Given this list of marker genes AP2B1, LRP6, PTPRO, ATCAY, ABHD17B, RIC3, STXBP3, QKI, AP3M2, ADAM10, CD53, NRG3, CAPZB, CNTNAP4, LRFN1, GABRA1, NOS1, PAK2, PTK2B, RALA, SEMA7A, SYNE1, KCNC2, GRIA2, GRIN1, RPL10A (NCBI Gene Id 4736), HTR3D, C1QBP, CALM1, C9orf72, CTNNB1, CNTN6, HCRTR2, EPHB1, EEF1A2, MIB1, GRIN3B, CRHR2, GRK2, VPS35, TULP1, ADGRL2, RAB11B, ATP6V1C1 (ATPase H+ transporting V1 subunit C1), OGT, RGS7BP, SH2D5, C1QA, DLG5, KPTN, SYN3, CNTNAP2, MTMR2, GNG13, KCNMA1, SYNJ2, AP3S1, ERBIN (NCBI Gene Id 55914), GRM1, ATP1B2, AKR1A1, NGFR, GPC1 (glypican 1), SPG11, ATP6V1A, PTPRS, ENAH, KCNN1, BEST1, SYN1, SIPA1L2, RPH3AL, PHAF1, PCBP1, NPTXR, KCNIP2, GABRB3, ARHGAP22, ANK3, PARK7 (NCBI Gene Id 113880), ADORA2B, MFF, TRIO, LAMA2, SLC16A1, YWHAH, GPR158, BCAN, NECTIN1, GNG12 (G protein subunit gamma 12), ADGRL3, SNAP23, CHRM5, MAGI2, KCNMB4, SYT10, SPOCK1, PPFIA3, PVALB, CPNE4, SIGMAR1, SLC30A1, GNG3, LNX1, PORCN, PPA2, CLMP, FXR1, RTN3, AP3B2, LINGO2, DISC1, ATG9A, GABBR2, SLC40A1, NTRK2, VAMP4, RPL30, FLNA, SH3GL1, RAB5A, GNAI2, STX2, RHEB, SLC6A1, ARHGAP12, TAGLN3, CACNB2, VTI1B, TRIM9, CNR2, IGF2BP1, GPHN, RPS20, ICAM5, NIPSNAP1, NF1, FAM81A, KALRN, ATP7A, KCNMB1, SLC1A7, ELFN2 (extracellular leucine rich repeat and fibronectin type III domain containing 2), MEF2C (NCBI Gene Id 4208), ACTL8, DBH, LRRC7, SCGN, SNAP91, SNAP29, GRIK2, DGKI, RPS3A (NCBI Gene Id 6189), CRTAC1, APBA1, CHRNA7, SYT13, EPS15, SPTBN1, TRPV1, DOCK1, ARL8B, CAPN2, DNAJC5, GPC2, KIF17, GDI1, ITGA3, RANBP6, FMR1, PAK5, PPP3CA, ACTB (actin beta), RAB40AL, NEDD8, CNP, PTPN1, PTPRD, SEPTIN4, PIAS3, CDH1, CNTN5, NPTX1, AGRN, MAPK8IP1, OMP, NEURL1 (neuralized E3 ubiquitin protein ligase 1), RAP1B, SLC12A5, OPRD1, ABHD6, TRAPPC4, GNAQ, NEO1 (neogenin 1), PGRMC2, NTS, GUCY1A1, BCL11A, VANGL2, METTL5, CDH6, CRK (CRK proto-oncogene, adaptor protein), ADARB1, HRH4, ATP2B1, GSK3B, GPR50, CAV3, TNR, RYK, ATP6V1G2, SRPK2, PLAA, KCNC3, SNCA, NTF4, KCNB1, ATP8A1, SYNJ1 (NCBI Gene Id 8867), CPT1C, SYAP1, VPS18, SRCIN1, MBP, EFNB1, YWHAG (NCBI Gene Id 96443), CORO1B (coronin 1B), TUBA1A, SNTB2, SEPTIN3, LASP1, CPSF2, NRGN, FLOT1, CAMK2N2, LRRC4B, CACNB3 (calcium voltage-gated channel auxiliary subunit beta 3), EPS8, IGSF21 (NCBI Gene Id 84966), ARHGDIA, CNR1, LIN7A, P2RX1, HTR3A, HOMER3, APBB2, LRIT1, ADRA2A, NWD2, LAMB2, CDK16, GAD2, PPP1CC, C1QL2, SLC1A3, ATP6V1E1, SLC24A2, ITSN1, PPP3R1, ATP1A3, NCKIPSD, NCAN, C1QL3, DLGAP2, USP5, ATP6AP1, RPL7, MINK1, RAPGEF4, EEA1, UBE2M, DGKZ, SYNDIG1, PLCB3, CALB2, PDE2A, HTT, P2RY1, PTCH1, SNX27, GPR176, CHRNA2 (NCBI Gene Id 1135), CTNND2, UNC5C, PJA2, LAMA5, PTPRN, NMNAT2, PCDHB11, CXADR, LRP4, PRKAR1A, SEZ6 (seizure related 6 homolog), SLC22A2, CLN8, YWHAZ, NDEL1, AAK1, ARFGAP1, EPHA7, CBARP, CHRNG, SLC6A9, STX11, ATP6V1G3, CACNG2, SPARCL1, BLTP1, SLC30A10, TOR1A, SYT6, CDKL5, SEMA3A, NEGR1, SNX9, OPHN1, ZDHHC2, RPS11, GAK, NSF, VAMP1, GABRG3, RAB40B, SRPX2, STX7, SLC1A2, MPP2, SLURP2, CLN3, HAPLN3, CRMP1, APH1A, RPL28, RPH3A, SLC6A17, SNPH, CRYAB, KCNJ10, CAMK2D, SV2A, SPTBN2, BAIAP3, BAIAP2, VASP, RPS16, GABRA5, SLC35G2, CDH10, SLC18A2, GPRIN3, CRELD1, RPL12, TANC2, CANX, WHRN, SLC1A4 (NCBI Gene Id 6509), FILIP1, RAB5B (RAB5B, member RAS oncogene family), CLSTN3, PCDHB2, KCNC4, P2RX3, LY6G6D (NCBI Gene Id 58530), RPS27, PMP22, ATG16L1, RASGRP2, CLCN5, GNAZ, DAPK1, ATP6V0C, ZNF804A, SLITRK3, SENP1, SYPL2, AP2M1, DGKE, SERPINE2, AP3M1, ABI3, MX1, SRGAP2C, LRRTM4, CHN2, SOS1, PACSIN2, DSCAML1, MCTP2, CC2D1A, EHD1, APOE (apolipoprotein E), KCNQ3, VAMP3, GPER1, PPFIA2, CRH, SYNGR1, SDK1, GRM2, VAMP7, DAAM1, MYO7A, SHISA7, NR1D1, SLC8A3, AKAP12, CALM3, ADRB1, FGF22, CACNA1C, BTBD8, STXBP2, NEFH, NXPH4, TPRG1L, NOS1AP, GNRH1, DNM1L, PTN, RGS8, ZDHHC12, NECAP1, ATP6V1F, SORBS2, SLC3A2, KCNJ2, TIAM2, PNKD, RPS6, HTR6, ITPR1, ADORA1, HAPLN1, PRKCI, PKP4, PPP2CA, VWC2, CLTA, ATM, MAF1, ROGDI, YWHAQ, GNB1, LATS1, KCTD16, MAP1B, ATP2B3, SNX14, HNRNPUL1, CDK5R1, CAMK2N1, MUSK, CDH15, PPP1R9A, SLC2A1, PFN1, LYN (NCBI Gene Id 4067), P2RX2, EIF4E, LARGE1, GRIN3A, NCK2, SEMA4F, CAPRIN1, NECAB2, RPS6KA1, GLRA1, NLGN4Y, RPL37, INSYN2A, LZTS1, TRIM47, SACM1L (SAC1 like phosphatidylinositide phosphatase), PSD, CACNA1G, GIPC1, SORT1, CHRM1, TMED9, CLCN2, DSTN, UBE3B, SDK2, SYDE1, ZDHHC5, PDLIM4, SLC32A1 (solute carrier family 32 member 1), HOMER2, TIAM1, FER1L5, EFR3A, DAGLA (diacylglycerol lipase alpha), CADPS, EIF5A, PCDHB16, PACSIN1, ARL8A, NRG1, SST, GABRA2, CPLX1, EGFLAM, RPL38, HPCA, BNIP3, PICK1, FGB, GLS, EFNB2, SYNGAP1, STAU2, APBA3, PCDHB13, PLS3, SIPA1L1, PRKN, DACT1, PRRT1, CAPN5, ARPC5L, EGLN1, RPL27A, CHRM4, HRAS, CIB2, MYO9B, PCDHB3, HNRNPA1, ARHGAP32, CHRNA4, ABHD17C, INPP4A, ARPC1A, RPS5, PHF24, CHRNA1, ADCY1, ARHGEF15, KIF2C, F2R, EIF3D, KCNQ2, AURKA, CD3E, GAP43 (NCBI Gene Id 2596), PALM, RGS9, PCLO, TENM2, CRIPT, TPGS1, USP46, LPAR3, CPEB3, PIAS1, AP1S1 (NCBI Gene Id 574017), GRN, FXYD6, WASF1, AKAP5, PRNP, RIMS1, DDN, MICAL1, SH3KBP1, SORCS2, HNRNPA0, NAPA, CPEB1, DLG2, TSC1, CHRND, SDCBP, SLC12A7, CASK, PIK3C3, ALDH5A1, ATP6V1H, NPFF, PRUNE2, SLC1A6, KCNQ5, TDRD1, ANO1, PLXNA1, PRR12, C1QC, DGKQ, UBE3A, SLC29A4, SMCR8, NPBWR1, PRKCB, RGS12, NGF, SNX4, VLDLR, SUMO2, DTNB, RTN4R (reticulon 4 receptor), EIF4EBP2, WNT3A, SHARPIN, ZDHHC8, IL1RAPL2, CNIH2, EEF2, NLGN2, OLFM3, SLC4A8, ZNRF2, SYPL1, MYRIP, SLC35F1, NSMF, ATG5, CPLX3, HRH3, SSH1, PAFAH1B1, MET, P2RX6, ATP2B2, ASIC1, ATP6V1D, PCDHB10, GNG7, RPL34, LAMP1, HTR2A, NPS, NLGN4X (neuroligin 4 X-linked), SLC17A6, KIF5B, EPS15L1, PPP3CB, OXT, RIT2, ACTG1, SHISA9, BAALC, NPPA, GPSM2, DNMBP, PPP1CA, ARF1, ABI1, SRGAP2B, CHRNA5, FAIM2, MPDZ, NEFM, EFNA2, ENO2, CALM2, MYCBPAP, VPS45, DOCK4, C4A, SNAP25, FCHO1, NRP2, MYO9A, VAMP2, AGAP3, C4B, UNC119, PPFIBP2, PPFIBP1, TANC1, HIP1, GNA13, CADPS2, SCN2B, GRIK5, CBLN3, NR3C1, GSK3A, GHSR, PSEN2, SEMA3F, STRN, HTR1A, SLC8A2, RPL31, CDH8, CAD, MYOF, GNB4, PPFIA4, FAM107A, ATP1A1, MCTP1, CHRNB3, LRRTM1, NPY2R, FLRT2, SNX6, SYP, SLC29A1, CD2AP, AP1G1, GRM6, SLC18A3, ADGRB2, COLQ, IGSF9, SLC2A4, ROR1, AKT1 (NCBI Gene Id 207), RAC3, EXT1, ARHGAP33, ABLIM3 (NCBI Gene Id 22885), DNM1, NAPEPLD, EPHB2, NPY5R, TRAF6, SLITRK4, ARR3, LRFN5, SH3GL3, NCDN, SLC2A13, P2RX4, GRIK1, VPS52, KCNA4, RGS7, AKAP7, RPL21, NTF3, PLD1, FLOT2, LRRTM3, RPS28, FCGR2B, RPL19, PDZRN3, CACFD1, IQSEC3, SHANK2, SEPTIN11, NQO1, ADAM22, MAP2K1, KCNJ4 (potassium inwardly rectifying channel subfamily J member 4), RPS3, PSD2, ARF6, ERC2, GABRG2, SGIP1, STAU1, CBLN4, AP2A2, AMOT, ACP1, PCDHB9, DMXL2 (NCBI Gene Id 23312), TMEM230, CABP4 (calcium binding protein 4), GRIP1, MAPK14, GLRA2, VWC2L (von Willebrand factor C domain containing 2 like), TNC, PSCA, SYT12, RPL7A, ATP6V0D1, SLITRK2, GRIA1, CHRNA9, CEP89, NRXN1, TSC2, MAPT, SYT9, ELMO1, RIMS2, SRSF10, ATP6V1G1, SCAMP5, CNTNAP1, SPHK1 (NCBI Gene Id 8877), RABEP1, ACTN1, TSPOAP1, SLC9A5, MTNR1B, KCNJ9, WASF2, CHRNB4, KIRREL3, POTEJ, LRRC4C, ACTC1, SLC6A13, LRRK2, GDI2, CAP1, IL1RAPL1 (NCBI Gene Id 4399), ASIC2, NAPB (NCBI Gene Id 63908, NSF attachment protein beta), BSN, IGSF8, CHRNB1, MYLK, GRID2IP, EIF5, JAK2, TAFA4, CDH23, SYN2, NCS1, S1PR2 (sphingosine-1-phosphate receptor 2), VDAC3, RMDN3, CHRNA10, GRIN2C, FUS, C1QB, SWAP70, FAAH, RAB7A, DROSHA, AGAP1, EFNA5, DBNL, SVOP, BRAF, DGKB, INA, MECP2, OPRM1, S1PR3, FCHSD1, PENK, EPB41L3, FXR2, GNA15, SNTA1, NTNG1, NUMBL (NCBI Gene Id 9253), RAP1A, WDR1, GABRR2, NPTX2, NXPH1 (neurexophilin 1), BCL2L1, DNAJA3, PLEKHA5, STXBP5, TAMALIN, RASGRF2, RAB17, KCND3, STXBP1 (NCBI Gene Id 6812), AP1G2, ADD2, PRR7, HCRTR1 (NCBI Gene Id 3061), PRKACA, HRH2, CDH11, ABI2, AP1B1, CLCN4, KPNA1, ATP6V0E2, TMEM163, EIF4A3, UTS2, FBXO45, PRRT2, SARM1, STON1, PLXNC1, LGI1, RELB, NPAS4 (neuronal PAS domain protein 4), CPNE7, NLGN1, DLGAP4, PDE7B, SYT1, ERC1, RPS14, THY1, CASR, GRIA3 (NCBI Gene Id 2892), VDAC1, GOPC, PLP1, SEMA4B, CDH13, NDUFS7, DYNLL2, PIP5K1C, LIMK1, SORCS3, NETO2, LYPD6, EIF2S2, MAP1A, CACNA1B (calcium voltage-gated channel subunit alpha1 B), RGS14, STX19, CLSTN1 (NCBI Gene Id 22883, calsyntenin 1), TPPP, COL4A5, PRICKLE1, FBXO41, RPS13, RPS15, NMU, GRM4, KCTD8, GHRH, SYNC, HRH1, STRN4, RAB8A, CORT, SLC30A3, NCKAP1, FRMPD2, PPM1H (NCBI Gene Id 57460), ACP4, RAD51, CACNB1, DRP2, HTR1B, PFN2, RPS6KA4, EIF3I, MYL7, PRKCG, GABRB1, NPHP4, CNIH3, COPS5, NTSR1, EIF3E, CACNG3, SEPTIN8, SLC35D3, TMEM240, LRRTM2, MDM2, HNRNPM, SLC22A1, RTN2, GABRB2, CTBP2, SNAP47, DYSF, WFS1, KCNA1, SNCAIP, STON2 (NCBI Gene Id 85439), SLITRK1, NDFIP1, RPS6KA2, LYPD1, PIANP, C22orf39, NCSTN, CLCN3, CAMK1, IGF1 (NCBI Gene Id 3479), KCND1, EMB, DNM2, PPP3CC, SRGAP2, CPEB4, COPS4 (NCBI Gene Id 95620), PPP2R1A (protein phosphatase 2 scaffold subunit Aalpha), RPL8, TMEM108, SCN10A, RAB3GAP1, ROCK1, SV2B (NCBI Gene Id 9899), PCDHB14, ANKS1B, CYP46A1, SYT11, STAT3, PTCHD1, PMCH, CPEB2, GPC6, SLC6A7, GHRL, EIF6 (NCBI Gene Id 3692), TACR1, DNM3, HTR4, TTYH1, CORO1C, RPS26, ADGRB1, POTEE (POTE ankyrin domain family member E), STX10, MT3, CEP112, DARS1, POTEI, NSG1, MAP1S, SPART, PCDH8, CACNG7, SLC6A6 (NCBI Gene Id 6533), SLC6A12, AP2S1, SPTB, VPS54, LRRC4, CDK5R2, ELK1, PLD2, GABRD, UCN3, HAP1, PCDH17, NOTCH1, SYT2, S1PR5, CABP1, GRIA4, FZD3, DAO, UBE2I, DIP2A, SLC17A8, BEGAIN, NUMB, VAPB, CACNA2D2, SHC4, CACNG8, AGO2, PCDHB4, RAB11A, CHRM2, RHOB, KIF3B, PPP1R9B, DTNA, HNRNPD, MACO1, SUMO1, CBLN1, CYFIP2, TENM4, DRD2, SYNPR, PCDHB5, TNN, FRRS1L, OPRK1, ATP2A2, PDE10A, SLC12A6, GALR3, RPS19, RAC1, MME, PDPK1, RPL24, SLC17A7, SLC6A2, MYLK2, SLC17A5, BACE1, CTBP1, GRIN2D, PSEN1, WASL, FAM171B, EIF3B, ITPKA, RPLP0, SNTB1, PLCB1, NTNG2, ELAVL1, FGF12, APP, SEMA4C, DOC2A, SYT8, SYT7, PDYN, ANK1, DGCR8, TLN2, CNTN1, MPZ, CHRDL1, CDK5, RAB8B, DIXDC1, SSPN, STX1B, GNG2, GJD2, RAB3B, GRIP2, KCND2, CORO1A, SYNGR2, SIPA1L3, SNCB, UTRN, STX12, ABLIM1, PDXP, CBLB, COMT, KCNA2, EIF3L, LRFN2, PAK6, USH1C, PAK3, FARP1, USP50, SLC4A10, RAB3C, STK38, FGF7, RPL13, RAB11FIP3 (RAB11 family interacting protein 3), ETV5, FGFR1, LIN7B, RAB40C, LHFPL4, S1PR1, VCAN, VAC14, GPC4, RIMBP2 (NCBI Gene Id 23504), CALY, DMD, GABBR1, RNF10, ACHE, ANP32E, S1PR4, TFRC, KCNH1, APPL1, PPP2R2A, SCRIB, BRSK1, ITGA2, CSPG5, GNAO1, AP3S2, PURA, PNISR, GABRR1, NEDD4, CNTN4, PLCXD3, RPL15, HNRNPL, NUDT3, HCN1, SH3GL2, CASKIN1, CHRNA6 (NCBI Gene Id 8973), ATP6V1B2, SCAMP1 (secretory carrier membrane protein 1), RTN4, RNF220 (NCBI Gene Id 55182), SCRN1, RPL22, TAC1, GABRQ, PI4K2A, RASD2, KIF1A, EGR3, SEPTIN5, DRD3, NDE1, EFNB3, EIF3F (eukaryotic translation initiation factor 3 subunit F), ATP6V1B1, KCTD12, RAB13, NRXN3, BLOC1S6 (biogenesis of lysosomal organelles complex 1 subunit 6), ADCY8, ABR, SNCG, DIAPH3, MYH9, KCNJ3, SLC1A1, CTNNA2, SLITRK5, IGSF9B, NRCAM, SYNGR3, AP3D1, FYN, ADGRB3, VPS26B (VPS26 retromer complex component B), LPAR1, PLXND1, ARPC2, RELA, RUSC1, CHRNA3, CDH2, OTOF, CELF4, ADORA2A, RAB3A, ERBB4, MLF2, PNOC, SLC18B1, CHAT, SRGAP3, DNAJB1, OPRL1, GOT1, NRXN2, FRMPD4, HTR2B, MAP1LC3A (NCBI Gene Id 84557), GSG1L, SYNGR4, AP1M1 (adaptor related protein complex 1 subunit mu 1), EXOC4, STRN3, ATP6V0A4, IL31RA, RABAC1, KIF5C, SYT3, SHANK3, RPL14, LRFN4, ADD1, PMCHL2 (pro-melanin concentrating hormone like 2 (pseudogene)), FZD5, RAB3GAP2, MAGEE1, RPL37A, RABGEF1, USP14, CRKL, ITSN2, RPL18A, GABARAP, PCDH9, SLC6A11, ADGRA1, RPL35A, WASF3 (NCBI Gene Id 10810), SEPTIN1, AGER, CARTPT, UNC13A, CNNM2, GABRG1, CTTN, HTR1E, RGS17, RIMS3, ABCC8, PIN1, CFL1, RAP2A, EPHA4, SHISA8, MAPK9, IQSEC1, CAMKV, SLC6A5, TNIK, HAPLN2, LIN7C, NETO1, ADORA3, AP2A1, LGI3, RAB40A, CHRNB2, KCNC1, SHISA6, RPS21, OLFM1 (olfactomedin 1), GIT1, NRP1, BORCS5, RHOA, GRIN2A, FGFR2, P2RX5, TMOD2 (tropomodulin 2), LY6E, COL13A1, HTR3E, PCDH10, RAPGEF2, CADM2, SLC9B2, MAPK8IP2, CNTN2, CACNA2D1, CACNB4, PALLD, PDE4B, BTBD9, ACTN4, CAMK2A, GPM6A, PRAF2, NRN1, EEF2K, HAPLN4, CACNA1E (NCBI Gene Id 777), GLRB, TSC22D4, CLU, BDNF, SLC8A1, RHOG, SNAPIN, ATAD1, ZMYND8, KCNA6, LRFN3, DENND1A, SENP5, GABRR3 (gamma-aminobutyric acid type A receptor subunit rho3), KCNK9, SYNPO, ATP6V0A1, ARF4, MX2 (MX dynamin like GTPase 2), KIF5A, PSD3, ERBB2, SUSD4, RIMS4, NSG2 (NCBI Gene Id 51617), HTR3B, PLXNA4, ACAN, DRD5, ARFGEF2, DLG4, GRIK3, DLGAP1, GRIPAP1, KCNK2, TBC1D24, MPST, VPS16 (VPS16 core subunit of CORVET and HOPS complexes), CYFIP1, FBXL20, GNG4, BIN1, ADAM11, SLC22A3, NINJ1, CAMK2B, RAB33B, CSMD2, MRTFB, SCN9A, RPS9, CASP3, CHD4, PTPRC, ARRB2, ELFN1, RPS6KA3, KCNK3, ATP2B4, GIT2, RNF112, HTR5A, TSNARE1, SLC38A6, WNT5A, DPYSL3, AKAP9, ZC4H2, PLXNB1, SLC6A3, OLFM2, ABHD17A, RPS23, ALS2, GPR151 (G protein-coupled receptor 151), PRKAR1B, GPR37, TH, RPS27A, GRM7, SLC18A1, MDGA1, DYTN, RPL36, SLC6A4, NAE1, ATXN1, RPS25, IQSEC2, ABL1 (NCBI Gene Id 25), MARK1, ANXA9, SLC12A4, RAB3D, RPL23, EIF5B, CTTNBP2, ITGB1, DLG1, CADM3, LZTS3, DPYSL5, GUCY1B1, DOC2B, NOG, ZNRF1, UNC13B, MYH10, KCNJ8, HTR1F, SEPTIN6, STX6, NUFIP1, GABRE, LY6S, CRHBP, GNAT2, SEPTIN2, KCNK1, ARL6IP5, KIFAP3, STX1A, GRM5, PRKAR2B, APBB1, HOMER1, FCHSD2, USP8, CHRM3, DLGAP3, CPLX4, KCMF1, DVL1, APOA4, SLC2A8, SHANK1, NLGN3, PARN, RPL27, TPBG, NPTN, SAMD4A, GABRA3, POSTN, ELMOD1, IL1RAP, GRID2, GRK3, ARHGAP44, UNC13C, GJC1, AMPH, PURG, DAB1, LYNX1, SYT4, CLTB, RAB12, GABRA4, ATP6AP2, PICALM, HTR1D, TRPC5, ACTN2, OSBPL2, HCRT, CHMP2B, SLC39A3, KLHL17, CLSTN2, ITGA8, PPT1, RPS7, SYT17, RPS18, LRP8 (NCBI Gene Id 7804), POTEKP, EIF3A, MOB4, PALMD (NCBI Gene Id 93975), ADGRL1, SYDE2, CALR, C1QL1, INSYN1 (inhibitory synaptic factor 1), HTR3C, DCC, USP6, TDRD5, DAG1, MKLN1, CARMIL3, YBX3, ARC, RS1 (NCBI Gene Id 6247), CAP2, GPR179, USH2A, DLG3, SEMA4D, GRIN2B, ALDH1A1, STX16, PPFIA1, HTR7, RAB26, PDZD11, PCDH15, BCR, GRAP, CAMK2G, FCHO2, MAPK3 (NCBI Gene Id 5595), NTN1 (NCBI Gene Id 9423), STAC3, KCNAB2, CACNG4, KCNN2, CRHR1, CUL3, NCAM2, NPY, GNB5, ADD3, PTPRN2, BMPR2, RPL13A, ITGA5, ZDHHC17, PGRMC1, CNRIP1, ITGB3, HNRNPUL2, HTR2C, NTRK3, SENP7, PLPPR4, DOK7, CPLX2, GABRA6, RPS10, GLRA3, RAPSN, P2RX7 (NCBI Gene Id 5027), KIF21A, GNA11, LAMP5, GRID1, POTEF, DES, TUBB2B (tubulin beta 2B class IIb), PLG, DSCAM, PHACTR1, TMUB1, KCNIP1, EIF1AX, RPL6, KIF1B, DNAJC6, RGS10, GNB2, GAD1, DBN1, DRD1, TRIP4, EIF2S1, HNRNPF, NECTIN3, CLASP2, ICA1, ATP1A2, FBXO2, PTPRZ1, SAMD14, RAB21, DMTN, ADAM23, CACNA2D3, ZMYND19, APBA2, PLAT, CDC42, MAPK1, CACNG5, PRKCE, ZDHHC15 (NCBI Gene Id 158866, zinc finger DHHC-type palmitoyltransferase 15), PSENEN, CALB1, IGSF11, GRM3, CADM1, ATXN3, PTEN (phosphatase and tensin homolog), SLC16A7, LPAR2, UCN, CNGB1, LY6H, VTI1A, CHRNE, STX4, STX3, SHROOM4, EZH2, FABP5, ARHGEF9, PCDHB6, SLC5A7, PRIMA1, PUM2, RAB4A (RAB4A, member RAS oncogene family), SV2C, CBLN2, DRD4, DTNBP1, GRIK4, RPS6KB1, ANK2, VCP, CNKSR2, CALCA, HNRNPLL, ARHGEF7, PRSS12, SQSTM1, BRINP1, NEFL, HIP1R, ABTB3, FZD4, YBX1, NPR2, MAPK8, RTN1, LRIT3, PDLIM5, DOCK10, SYT5, FLRT3, RAB27B (RAB27B, member RAS oncogene family), WNT7A, NGEF, ACTBL2, ARHGAP39, CHRFAM7A, here is a description of the gene set: species: Homo sapiens The junction between an axon of one neuron and a dendrite of another neuron, a muscle fiber or a glial cell. As the axon approaches the synapse it enlarges into a specialized structure, the presynaptic terminal bouton, which contains mitochondria and synaptic vesicles. At the tip of the terminal bouton is the presynaptic membrane; facing it, and separated from it by a minute cleft (the synaptic cleft) is a specialized area of membrane on the receiving cell, known as the postsynaptic membrane. In response to the arrival of nerve impulses, the presynaptic terminal bouton secretes molecules of neurotransmitters into the synaptic cleft. These diffuse across the cleft and transmit the signal to the postsynaptic membrane. Human Gene Set: GOCC_SYNAPSE